The following is a description of a gene set: Genes predicted to be targets of miRBase v22 microRNA hsa-miR-4537 in miRDB v6.0 with MirTarget v4 prediction scores > 80 (high confidence targets). from publication Chen Y, Wang X (PMID 31504780) species: Homo sapiens Human Gene Set: MIR4537, and this is the list of marker genes: ANKRD16, MPV17L, MDM4, ZNF587, CA12, PCMTD2